The following is a description of a gene set: electronically inferred by orthology from the curated human pathway This event has been computationally inferred from an event that has been demonstrated in another species.<p>The inference is based on the homology mapping from PANTHER. Briefly, reactions for which all involved PhysicalEntities (in input, output and catalyst) have a mapped orthologue/paralogue (for complexes at least 75% of components must have a mapping) are inferred to the other species. studied in species Mus musculus part of: Assembly of the 9+0 primary cilium Reactome Pathway: Anchoring of the basal body to the plasma membrane, and this is the list of marker genes: Cep152, Mks1, Cep43, Rab8a, Cep290, Nphp1, Clasp1, C2cd3, Cep41, Cdk1, B9d1, Ywhae, Nde1, Haus8 (NCBI Gene Id 76478), Cep57, Rab11a, Tctn2, Rab3ip, Prkaca, B9d2, Cep89, Sdccag8, Csnk1e, Haus5, Tubb4a, Cep131 (NCBI Gene Id 12009), Cep72, Actr1a, Ninl, Sfi1, Haus1, Tubb4b, Nedd1, Dctn1, Cep83, Cenpj, Cep135, Prkar2b, Dynll1, Tuba1a, Plk1, Tctn3, Cep192, Haus7, Cep63, Tuba4a (tubulin, alpha 4A)